Given this list of marker genes N4BP1, GRN, TOP2A, CAT, ECM1, DSC2, EIF1AX, KLK7, B4GALT1, ANXA4, LGALS3BP, KLK10, CSNK1A1, RFC5, MICU2, C1QBP, SCFD1, PRKCI, DSTN, LLGL1, SMC3, ZWINT, HLA-DQA1, HLA-DQB1, BCLAF1, TNFSF10, ITGA6, here is a description of the gene set: PURPOSE: Increased production of Th2 cytokines characterizes Sezary syndrome, the leukemic form of cutaneous T-cell lymphomas (CTCL). To identify the molecular background and to study whether shared by the most common CTCL subtype, mycosis fungoides, we analyzed the gene expression profiles in both subtypes. EXPERIMENTAL DESIGN: Freshly isolated cells from 30 samples, representing skin, blood, and enriched CD4(+) cell populations of mycosis fungoides and Sezary syndrome, were analyzed with Affymetrix (Santa Clara, CA) oligonucleotide microarrays, quantitative PCR, or immunohistochemistry. The gene expression profiles were combined with findings of comparative genomic hybridization of the same samples to identify chromosomal changes affecting the aberrant gene expression. RESULTS: We identified a set of Th1-specific genes to be down-regulated in Sezary syndrome as well as in a proportion of mycosis fungoides samples. In both Sezary syndrome and mycosis fungoides blood samples, the S100P and LIR9 gene expression was up-regulated. In lesional skin, IL7R and CD52 were up-regulated. Integration of comparative genomic hybridization and transcriptomic data identified chromosome arms 1q, 3p, 3q, 4q, 12q, 16p, and 16q as likely targets for new CTCL-associated gene aberrations. CONCLUSIONS: Our findings revealed several new genes involved in CTCL pathogenesis and potential therapeutic targets. Down-regulation of a set of genes involved in Th1 polarization, including the major Th1-polarizing factor, TBX21, was for the first time associated with CTCL. In addition, a plausible explanation for the proliferative response of CTCL cells to locally produced interleukin-7 was revealed. from publication Hahtola S, Tuomela S, Elo L, Häkkinen T, Karenko L, Nedoszytko B, Heikkilä H, Saarialho-Kere U, Roszkiewicz J, Aittokallio T, Lahesmaa R, Ranki A (PMID 16914566) Genes down-regulated in lesional skin biopsies from mycosis fundoides patients compared to the normal skin samples. Human Gene Set: HAHTOLA_MYCOSIS_FUNGOIDES_SKIN_DN species: Homo sapiens